The following is a description of a gene set: Mouse Gene Set: MIR_181D_5P species: Mus musculus from publication Chen Y, Wang X (PMID 31504780) Genes predicted to be targets of miRBase v22 microRNA mmu_miR_181d_5p in miRDB v6.0 with MirTarget v4 prediction scores > 80 (high confidence targets)., and this is the list of marker genes: Iqschfp, Zfp973, Gm6712, Mideas, Tmem165, Ncoa2, Slc25a36, Hoxa1, Klhl29, Zfp966, Agfg1, Pcdhac2, Tgfbr1, Ubl3, Carf, Pbx1, Apba1, Txndc12, Fnip2, Zfp36l2, Lhx9, Zfp931, Adamts5, Zfp975, Tbc1d1, Crim1, Gm14322, Nwd2, Rnmt, Gse1, Bclaf1, Schip1, Palb2, Qser1, Map4k4, Ythdf3, Umad1, Sema4g, D430041D05Rik, Scamp2, Slitrk1, Bhlhe40, Tnfrsf11b, Etl4, Ddx55, Gm6710, Rai1, Zfp317, Kcnq5 (NCBI Gene Id 77687), Dennd4c, Tspan13, Ipo8, Mybl1, Plekhj1, Zfp280d, Tns1 (tensin 1), 2210418O10Rik, Mier3, Zfp850, Pdap1, Tsc22d2, Dclk1, Gigyf1, Ssx2ip, Lox, Hey2, Dnajc21, Cpne2, N4bp2, Cyp2c39, Zfp980, Cpd, Zfp951, Zfp960, Atg5, Rala (NCBI Gene Id 80577), Pals1, Zfp800, Acsl4, Gpr22, Psap, Drd1, Cpeb4, Oxsm, Gls, Ralgapb, Pcdha12, Gm14391, Pou2f1, Sfmbt1, Sec24a, Zfp1008, Grm5, Dlgap2, Sgpp1, 1700066M21Rik, Dio2, Nmnat3, Patl1, Gatm, Slf2, Crebrf, Pcdha2, Zfp965, Hsp90b1, Ino80d, Kcnh1 (potassium voltage-gated channel, subfamily H (eag-related), member 1), Zfp958, Thrb, Nek7, Zfp36l1, Hycc2, Cbx7, Jarid2, Lif, Tent4b, Mdh1b, Gpd1l, Nr2c2, Trim2, Kpnb1, Adarb1, Smap1, Mb21d2, Hmbs, Prox1, Phlda1, Ttc39b, Grb10, Zfp976, Rufy3, Spink2, Zfp600, Ap1s3, Trub1, Chic1, Atf7ip2, Lmo1, Ppfia1, Nexmif, Igdcc3, Arf6, Xpo7, Larp4, Ythdc2, Ss18l1, Ap1g1, Taok1, Mpi, Mtpn, Klf15, Lyrm1, Ippk, Acvr2b, Zfp619, Zic2, Prtg, Tcerg1, Trak1 (trafficking protein, kinesin binding 1), Zbtb43, Morc3, Zfp101, Slc25a37, Fam3c, Slc2a3, Zfp704, Abi3bp, Dlg2, Nkain2, Sik3, Ago2, Tecpr2, Peak1, Zfp810, Esm1, Limch1, Gpd2, Atxn1, Cnksr2, Cecr2, Lrrc32, Dock4, Sec24c, Adamts1, Rorb, Arl13b, Kmt2c, Pcdha5, Stim2, Trim71, Jade2, Zdhhc7, Lin28b, Greb1l, Gskip, Wsb1, Grik2, Tab3, Ubp1, Tulp4, Cbfa2t3, Rex2, Mamdc2, Gata6, Gm14296, Zfp935, Mboat2, E2f5, Ddx3x, Zbtb41 (zinc finger and BTB domain containing 41), Mfsd6, Zfp1009, Pax9, Rbbp7, Pcdha1, Pnisr, Zfp970, Usp33, Hibch, P2ry10, Brd1, Fbxo33, Epha4, Baz2b, Epc2, Prom2, Dmxl2, Htr1f, Stxbp6, Zfp867, Zfp808, Rassf1, Cpsf6, Prrc2c, Fign, Sox6, Jdp2, Gm14326, Zfp869, Ttl, Zfp781b, Dusp6, Slc7a13, Nus1, Esco1, Spry4, Mmp14, Pi15 (NCBI Gene Id 94227), Afg3l2 (AFG3-like AAA ATPase 2), Mturn, Ppip5k2, Sin3b, Cfap90, Hic2, Tnfsf10, Nr6a1, Dnaja4, Zfp458, Bend3, Lrba, Nr3c1, Slc4a10, Bcl2l11, Rbm46, Prdm4, Ttpa, Zbtb4, Prkcd, Kcna4, Glrb (glycine receptor, beta subunit), Cdyl (chromodomain protein, Y chromosome-like), Ube2b, Mlf1, Nova1, Klhl42, Hoxa11 (homeobox A11), Pcdha9, Carm1, Atp2b3, Armcx3, Zic3, Adamtsl1, S1pr1, Cnksr3, 2010315B03Rik, Dram1, Togaram1, Pcdha3 (protocadherin alpha 3), Golga1, Osbpl8, Fmnl2, Cdon, Kmt2a, Lclat1, Msantd3, Nr1d2, Nab1, Pcdha7, St8sia4, Papolg, Abtb2, Anapc16, Rlim, Hipk3, Sowaha, Spice1, Atp2b1, Eya3, Cntn4, Usp42, Specc1l, Heca, H2-K1, Ptbp3, Esr1, Pdcd6ip, Pcdha6, Cblb, Htr1a, Pcdha4 (protocadherin alpha 4), Rps6kb1, Man2a1, Ercc8, Rassf8, Slc35f3, Rps6ka3 (ribosomal protein S6 kinase polypeptide 3), Dnajc13, Gm14325, Mycbp2, Dcbld2, Gpsm1, Ap4e1, Gm20939, Ipmk, Zfp930, Zfp967, Cluh, Dido1, Rad21, Plcl2, Wdr82 (NCBI Gene Id 77305), C2cd5, Osbpl3, Itsn2, Entpd6 (NCBI Gene Id 72561), Etv6, Nfat5, Rsad1, Srsf7, Zfp934, Ahnak, Wnk1, Pcdha8, Pknox2, Adcy9, Septin8, Zdhhc17, Clip1, Scyl3, Adam11, Tada2b, Pabir2, Aldh3a2, Rnf182, Acvr1c, Rhoh, Mfsd1, Ncald (NCBI Gene Id 78450), Clasp2 (CLIP associating protein 2), Ercc5, Pcdha11, Birc6, Pcdha10, Btbd3, Syne1, Ppp3r1, Zfp971 (zinc finger protein 971), Tmem94 (NCBI Gene Id 71947), Phtf2, B4galt1, Spire1, Mtx3, Cdc40, Gabra1, 5730507C01Rik, Ankrd44, Zfp120 (NCBI Gene Id 320490), Clasp1, Adamts6, E2f7, Cdc42bpa, Rin2, Clec10a, Tmeff1, Zfp97, Zbtb7a, Rbm26, Tmed4, Atp2b2, Naa15, Mapk1, Ccp110, Zfp825, Hoxc8, Gfpt1 (NCBI Gene Id 72178), Klhl5, Tbc1d4, Ccnj, Phf20l1, Klf6, Cep97, Nucks1, Tnfaip1, Mtf2, Med8, Sim1, Il1a, Zfp936, Pi4k2b, Rnf34, Pcdhac1, Zfp780b, Ccdc122, Zfp14, Ano1, Lemd3, Rabgef1, Lrrc8e, Nr4a3, Cacnb2, Creb1, Tnf, Nipal4, Spty2d1